The following is a description of a gene set: During acute viral infections, naïve CD8+ T cells differentiate into effector CD8+ T cells and, after viral control, into memory CD8+ T cells. Memory CD8+ T cells are highly functional, proliferate rapidly upon reinfection and persist long-term without antigen. In contrast, during chronic infections, CD8+ T cells become “exhausted” and have poor effector function, express multiple inhibitory receptors, possess low proliferative capacity, and cannot persist without antigen. To compare the development of functional memory T cells with poorly functional exhausted T cells, we generated longitudinal transcriptional profiles for each. species: Homo sapiens Human Gene Set: GSE41867_NAIVE_VS_DAY30_LCMV_CLONE13_EXHAUSTED_CD8_TCELL_UP Genes up-regulated in CD8 T cells: naïve versus exhausted at day 30 chronic infection with LCMV-clone 13. from publication Doering TA, Crawford A, Angelosanto JM, Paley MA, Ziegler CG, Wherry EJ (PMID 23159438), and this is the list of marker genes: IL19, MIR155HG, RNF213, TP53INP2, GTPBP1, LAG3, FAM174B, DNAI3, TNIP2, BAZ1A, GNGT1, TSHB, PIK3R3, SCGB2A1, HERC6, OTUD4, NEDD4L, MAP2K3, RNF19A, NAMPT, APOBEC3A, MAP4K4, WDR97, RAB24, PRSS23, PPP1R15A, PLK3, DGKH, SERPINE1, SIPA1L1, SPAG1, GJB2, TNS2, SHFL, NINJ1, XRN1, SDC4, REN, PIM3, RNF144B, MX2, DDX60L, BHLHE22, EHD4, EPSTI1, PPFIBP2, PRG3, VCAN, EREG, STX11, ADORA2A, NXF1, SAMD9L, FUT4, TENT4A, IL6, APOL1, OAS3, TSPO2 (NCBI Gene Id 222642), KCNJ2, CCL4 (NCBI Gene Id 6351), SNHG15, ABTB2, PLEK, CLEC2D, BAALC, PI4K2B, ENSG00000291006, CD40, HELZ2, STAT1, TDRD7, IL18R1, ZBTB10, DMRT2, TRIM22, SNN, CSRNP1, IFIH1, P2RX7, WTAP, EHD1, CFLAR, FCGR1BP, LINC01588, ANKLE2, STARD5, SLC1A3, CDC14C (NCBI Gene Id 168448), NOCT, PALM3, DNAAF1, RBBP6, POPDC2, HSF4, DAPP1, ISX, MASP1, IL18RAP, PVR, CPNE8, ARAP2, TAAR5, PTPRF, IL7R, RBMXL1, OASL, IMPG1, TYSND1, P2RX4, GPR183, TTN, LYN, ADAR, MEST, TSIX, UBE2L6, LINC01785, USP18, PIWIL4, MXD1, STAT5A, C15orf32, ADM, CPLANE1 (NCBI Gene Id 84157), SORBS1, IFI35, PARP14 (poly(ADP-ribose) polymerase family member 14), CD83, AMPD3, MYO1A, FBXO40, UST, SPATA6, PRX, MAP3K8, FBP2, PELI1, GCH1 (NCBI Gene Id 93984), DUSP5, FXYD6, PTK2B, PTGS2, SKIL, ERRFI1, ENSG00000280119, ZNFX1, PTGER2, B4GALT5, KRT17, C3orf38, OAS1, IDO2, MCTP1, CXorf65 (chromosome X open reading frame 65), GPR32, ASAP2, TNIP3, SLAMF1, AIM2, BLVRA, TRIL, CCL5, PML (NCBI Gene Id 5371), RIGI, ADAMTS2, EGFL7, BIRC2, CXCL9, PSD3, BLZF1, ZC3HAV1, GRHL1, NECTIN3, ESPL1, SLC1A2, MIR3945HG, PIK3R5, HERC5, CDKN2B, SLAMF7, NPY1R, RIPK2, EGFLAM, CELA1, SERPINB1, ABCC2, RIPK1, ARHGAP27, C4orf46, KRT80, NCF1C